The following is a description of a gene set: species: Homo sapiens Nanoparticle-mediated activation of receptor signaling Human Gene Set: WP_NANOPARTICLEMEDIATED_ACTIVATION_OF_RECEPTOR_SIGNALING, and this is the list of marker genes: MAP2K2, MAPK8, NRAS, MAPK9, AKT3, GRB2, PTK2, MAPK14, PXN, COL1A1, MAPK11, FN1, AREG, SRC, MAPK1 (mitogen-activated protein kinase 1), TLN1, MAPK10, ITGA1, KRAS, HRAS, PIK3CD, EGFR, ITGB1, MAP2K1, SOS1, MAPK13, MAPK12, RAF1